Given this list of marker genes FAM3B, CPT1A, G6PC2, UCN, C2CD2L, SSTR5, MLXIPL, RAB11FIP3, TRPA1, GIP, CCN3, OSBP, TUBB1, SLC16A2, PLA2G6, SLC8B1, DRD2, FFAR1, CHGA, CRY2, GIPR, GALR1, ADCYAP1, GLUD1, RETN, BTK, PDX1, SIDT2, FOXO1, TUNAR, RAB11FIP2, CASR, SLC7A8, IL1RN, VAMP7, ANXA1, STX1A, ACSL4, SCT, ZBED6, SMAD2, GNAO1, PRKACA, GNAI1, BMP6, LTBP4 (NCBI Gene Id 8425), KCNB1, SLCO1C1, SLC9B2, F2, RBM4, NKX3-1, SLC3A2, PAX8, MPC2, ABCB1, JAGN1, DAB2, ILDR1, PCLO, PTPRN2, HLA-DRB1, GPR119, TBX3, NMU, FGF23, RAPGEF4, TRPM4, VIP, MAFA, PPARD, OPRK1, RAB44, REST, PIM3, SERPINA7, FFAR4 (free fatty acid receptor 4), GPRC6A, ACVR1C, UCN3 (urocortin 3), SIRT3, STXBP4, MYB, HNF1B, PFKM, CLTRN, KDM5B, AGTR1, OXCT1, CHRM3, PTPN11, SNAP25, ADRA2A, UBE2Q1, PRKCA, FZD4, IRS2, RAB8B, ENSA, RAF1, PLCB1, EPHA5, APLN, NMB, CAMK2G, GPR68, SLC2A2, RAB3A, GLP1R, PSMD9, PCK2, SLCO4A1, CCKAR, GHRL, FAM3D, CLOCK, DOC2B, GAL, FGG, SOX11, VAMP2, TCF7L2, C1QTNF1, KLF7, GATA3, TRH, CARTPT, FKBP1B, PLA2G3, PPP3CB, GCK, LIF, TARDBP, PRKCB, ADCY5, CCL5, HCAR2, GRP, HFE, KCNJ11, SIRT6, PTPRN, SELENOM, HTR1A, FOXA2, SRI, F2RL2, NIBAN2, EIPR1, ACVR2B, STX4, EDN3, MYRIP, FGFR1 (fibroblast growth factor receptor 1), BAD, AACS, FGA, TAC1, SOX4, ISL1, MIDN, ITSN1, GPLD1, TNF, PRKD1, SNAP23 (NCBI Gene Id 8773), PRKCE (NCBI Gene Id 5581), IRS1, NNAT, GNRHR, CREB1, NOS2, SYT7, PFKFB2, SCG5, LRP5, VSNL1, PPARG, RAB1A, TOR2A, FFAR3, SPP1, CPLX1, PDE8B, BAIAP3, AIMP1, NEUROD1, SNX4, F2RL1, SLC17A4, PARK7, KCNQ1, MC4R, POMC, HMGA2 (NCBI Gene Id 8091), TFAP2B, ADIPOQ, IL1B, RPH3AL, BMAL1, SREBF1, STXBP3, RIMS2, TACR1, CD38, TRPV4, UCP2, ORAI1, HIF1A, CRHR1, INS, TACR2, GHSR, PHPT1, SLC22A9, SMAD4, GHRHR, NDUFAF2, SYBU, OSM, AQP1, RFX6, MTNR1B, BMP8A, CELA2A, RBP4, HTR2C, ADRA2C (NCBI Gene Id 152), FOXL2, SLC16A10, LYN, CCDC186, NADK, CDK16, NPFF, GNAS, INHBB, RFX3, ABAT, ILDR2, TFR2, VAMP3 (NCBI Gene Id 9341), FAM3A, HADH, CAPN10, SERP1, CYB5R4, CPLX3, CYP19A1, GABBR1, GHRH, GCG, CPE, INHA, NLGN2, TRPV6, GNA11, FGB (fibrinogen beta chain), ITPR1 (NCBI Gene Id 619543), GPER1, TM7SF3, NR0B2, BRSK2, C1QTNF3, MCU, KCNA5, VGF, SELENOT, RAPGEF3, ADCY8, NR1H4, CGA, SLCO1B1, NR1D1, PRKAR1A, LEP, AGT, UQCC2, INHBA, PRKN, HNF4A, SLC16A1, IL6, KCNK9, CRH, HNF1A, RAB11B, GPR27, WNK4, SNX19, SMPD3, FOXD1, DYNLL1, CFTR, ENY2, TSPO, RAB11FIP5, TMF1, CRYM, TNFSF11, SIRT4, P2RY1, RAC1, SLC30A8, PFKL, EXOC3L1, SLC7A5, PICK1, PER2, NPVF, KCNK16, LRRC8A, CRY1, BLK, GDF9, C1QTNF12, RAB11FIP1, SYTL4, TCIRG1, ALOX5, REN, GJA1, SNX6, IFNG, CRHBP, FFAR2, EFNA5, ECRG4, PASK, SLC18A2, IL11, ADORA1, VAMP8, EDN1, ANO1, ABCC8, JAK2, ABCA12, CHD7, TRPM5, SLC25A22, GNAZ, NKX6-1, RASL10B, here is a description of the gene set: Human Gene Set: GOBP_HORMONE_TRANSPORT The directed movement of hormones into, out of or within a cell, or between cells, by means of some agent such as a transporter or pore. studied in species Homo sapiens